The following is a description of a gene set: Genes up-regulated in CD8 T cells treated by interferon alpha: STAT1 knockout versus STAT4. from publication Gil MP, Ploquin MJ, Watford WT, Lee SH, Kim K, Wang X, Kanno Y, O'Shea JJ, Biron CA (PMID 22968462) species: Homo sapiens Human Gene Set: GSE40666_WT_VS_STAT1_KO_CD8_TCELL_WITH_IFNA_STIM_90MIN_UP Type 1 IFNs can conditionally activate all of the signal transducers and activators of transcription molecules (STATs), including STAT4. The best-characterized signaling pathways use STAT1, however, and type 1 IFN inhibition of cell proliferation is STAT1 dependent. We report that type 1 IFNs can basally stimulate STAT1- and STAT4- dependent effects in CD8 T cells, but that CD8 T cells responding to infections of mice with lymphocytic choriomenigitis virus have elevated STAT4 and lower STAT1 expression with significant consequences for modifying the effects of type 1 IFN exposure. The phenotype was associated with preferential type 1 IFN activation of STAT4 as compared to STAT1. Stimulation through the TCR induced elevated STAT4 expression, and STAT4 was required for peak expansion of antigen-specific CD8 T cells, low STAT1 levels, and resistance to type 1 IFN-mediated inhibition of proliferation. Thus, a mechanism is discovered for regulating the consequences of type 1 IFN exposure in CD8 T cells, with STAT4 acting as a key molecule in driving optimal antigen-specific responses and overcoming STAT1-dependent inhibition of proliferation., and this is the list of marker genes: ENTREP3, SOCS5, SLC16A3, IQGAP2, SQOR, IMP4, BTBD6, EID2, LATS2, FANCF, DAAM1, ZNF655, GRWD1, IGKC (NCBI Gene Id 3514), LRRN4, WWP1, SLC49A4, LRFN5, SLC40A1, FZD5, TTC9C, BANK1, ORAI2, HYAL3, PKP3, HERPUD1, KDM7A, MAP3K14, SLC35D2, PRR13, LENG9, TMED8, ANXA1, CLIP1, ARRDC4, C8orf58, GNPTG (N-acetylglucosamine-1-phosphate transferase subunit gamma), STT3B, TAMALIN, FHDC1, TPRG1L (NCBI Gene Id 127262), MRPL38 (NCBI Gene Id 64978), ESYT2, SLC25A20, RFLNB (refilin B), SCLY, GBE1, PRF1, BRME1, GPR183, LPAR6, MBNL3, NSMAF, TRMO, FBXL14, LYPD6B, SPRTN (NCBI Gene Id 83932), POLR1G, RNH1, HSD11B1, LNX2, SGK1, RNF32, RGS6, MRM1, AP1S2, SYNPR, BBS2, TRAF3IP2, TIGAR, NFATC1, BMP2K, CCNB1IP1, SCTR (NCBI Gene Id 6344), AP1M2, ARL13B, MVP, MYO6, PRDM1, ADGRB2, POLR1D (RNA polymerase I and III subunit D), TMEM243, VPS28, PMP2 (NCBI Gene Id 5375), DEDD2, RPS19, CDIPT, TNFSF14 (NCBI Gene Id 94566), SIPA1L2, ADH1C (NCBI Gene Id 126), PRXL2C, AR, ZNF764, NCK1, EXOSC1, C9orf152, DSTN, GLYCTK, CNN2, RAB33B, KRTAP7-1, EPS15 (epidermal growth factor receptor pathway substrate 15), KIFBP, SLC4A1AP, NR1D2, RNF216, BAG3, ATF4, VMAC, PARD6B, SMPDL3A, SQLE, ATP7B, TBX19, GCAT, GGACT, EHD3, SLPI, ANTXR2, SEMA4F, IDH1, KLF17, TRMT10C, BIK, PIP4P2, RCHY1, FAM210B, APOBR, FBXL4, PDE2A, ETFBKMT, FECH, FBXO22, TUSC2, NCF4, ADORA2A, WDR5B, SLC16A5, DAGLB (NCBI Gene Id 221955), TPPP, TMEM63A, AUH, SELENOP, PCED1B, RHOC, ECI1, ATP10B, ARHGAP5, TXNIP, GIMAP7, POC1B, RO60, ZBTB6, DCXR (dicarbonyl and L-xylulose reductase), SGMS1, DENND5A (DENN domain containing 5A), C10orf88, CRTAM, DENND1B, FUT11, CREBL2, ARL1, MAF1, PTPN14 (protein tyrosine phosphatase non-receptor type 14), TNFAIP8L2, SLC2A1, FBXO8, OSGIN1, TMEM273, STAT4, POU2AF1, OSBPL9, GPR34, TTC28, THADA, GNA15, LRRIQ4 (NCBI Gene Id 344657), ABCB10, TPST2, OARD1, UNC119, GPN1, ADGRE5, RPL6, PDE5A, CHAC2, GPD1L, N4BP2L1, ATXN1 (NCBI Gene Id 7912), TTC39B, PTGES2, SLC28A2, PPM1K, VTI1B, TIAM2, ARHGAP26, CERS4 (ceramide synthase 4), CEBPG, ZNF490